Given this list of marker genes EMP3, SNAI2, GNB4, VIM, SNAI1, CCDC88A, MSN, ZEB2, IKBIP, CMTM3, BICD2, QKI (NCBI Gene Id 9444), AP1M1, ZEB1, STARD9, here is a description of the gene set: Human Gene Set: KOHN_EMT_MESENCHYMAL Mesenchymal phenotype associated genes from an Epithelial-Mesenchymal Transition (EMT) gene set allowing sample stratification into epithelial, mesenchymal, and epithelial-mesenchymal categories initially developed on the NCI-60 cell line collection. species: Homo sapiens Expression-correlated genes were derived from data for the NCI-60 human tumor cell lines, as well as data from the Broad Institute's CCLE cell lines. NCI-60 cell lines that selectively expressed a mutually correlated subset of tight junction genes served as a signature for epithelial-like cancer cells. Those signature cell lines served as a seed to derive other correlated genes, many of which had various other epithelial-related functions. Literature survey yielded molecular interaction and function information about those genes, from which molecular interaction maps were assembled. Many of the genes had epithelial functions unrelated to tight junctions, demonstrating that new function categories were elicited. The most highly correlated genes were implicated in the following epithelial functions: interactions at tight junctions (CLDN7, CLDN4, CLDN3, MARVELD3, MARVELD2, TJP3, CGN, CRB3, LLGL2, EPCAM, LNX1); interactions at adherens junctions (CDH1, ADAP1, CAMSAP3); interactions at desmosomes (PPL, PKP3, JUP); transcription regulation of cell-cell junction complexes (GRHL1 and 2); epithelial RNA splicing regulators (ESRP1 and 2); epithelial vesicle traffic (RAB25, EPN3, GRHL2, EHF, ADAP1, MYO5B); epithelial Ca(+2) signaling (ATP2C2, S100A14, BSPRY); terminal differentiation of epithelial cells (OVOL1 and 2, ST14, PRSS8, SPINT1 and 2); maintenance of apico-basal polarity (RAB25, LLGL2, EPN3). from publication Rajapakse VN, Luna A, Yamade M, Loman L, Varma S, Sunshine M, Iorio F, Sousa FG, Elloumi F, Aladjem MI, Thomas A, Sander C, Kohn KW, Benes CH, Garnett M, Reinhold WC, Pommier Y (PMID 30553813)